The following is a description of a gene set: Mouse Gene Set: GOBP_DEFENSE_RESPONSE_TO_GRAM_POSITIVE_BACTERIUM Reactions triggered in response to the presence of a Gram-positive bacterium that act to protect the cell or organism. studied in species Mus musculus, and this is the list of marker genes: Havcr2, Adm, Ang6 (angiogenin, ribonuclease A family, member 6), Pglyrp3, Krt6a, Zg16, Rnase2b, Abcc1, Lyz1, Nlrp3, Ear2, Gbp9, Chga, Pglyrp4, Ctsg, Fau, H2bc12, Ang2, Il18 (NCBI Gene Id 16173), Tnfrsf14, C5ar1, Defa39, Ifng, Pycard, Rnase9, Gbp10, Defa37, H2-T23, Lbp, Npy, Defa22, Ang4, AY761185, Il17f, Gsdmd, Gbp7, Il27ra, Pla2g1b, Tnfsf8, Ang5, Defb10, Rpl39, Lyz3, Stab2, Defb1, Mmp7, Tlr2, Lta, Tnf (tumor necrosis factor), Myo1f, Defb2, Tbk1, Defa3, Defb21, Camp, Card9, App, Mbl2, Epha2, Defa20, Vip, Adam17, Gbp2, Defa5, Defb20, Defa26, Ear14, Rnase12, Klrk1, Pla2g2a, Dmbt1, Defb39, Ncf1, Defa28, Defb11, Gpr15lg (G protein coupled receptor 15 ligand), Lyg2, Defa17, Defb40, Mr1, Defb42, Cd36, Defa29, Reg3g, Defa38, Romo1, Sprr2a1, Rnase11, Rnase2a, Rnase6, Defa40, Hck, Ripk2, Mpeg1, Defa30, Il7r, Defa24, Pglyrp1, Seh1l, Rnase1, Scd1, Lyg1, Mbl1, Il1b, Defb4, Reg3b, Defb38, Defb8, Defb19 (defensin beta 19), Defb9, Lalba, Casp4, Ear6, Pld1, Hmgb2, Drosha, Ltf, Defa41, Defa35 (defensin, alpha, 35), Nod2, Gbp3, Ang, Ssc5d, Gbp6, Defa21, Il17a, Gbp2b, Defb37, Gbp4, Rnase10, Tirap, Pglyrp2, Defa25, Fgr, Rnase4, Sprr2a3, Hamp2, Rarres2, Defa23, Ppp1r11, Lyz2, Defa31, H2bc21, Defa2, Defa34, P2rx7, Gbp8, Tac1, Acp5, Defa42, Nlrp6, Ear1, Ear10, Hamp, B2m, Tnfaip8 (NCBI Gene Id 106869), Nod1 (nucleotide-binding oligomerization domain containing 1), Rnase13, Myd88, Mpo, Pfpl